The following is a description of a gene set: species: Mus musculus Mouse Gene Set: GOBP_NEGATIVE_REGULATION_OF_G_PROTEIN_COUPLED_RECEPTOR_SIGNALING_PATHWAY Any process that stops, prevents, or reduces the frequency, rate or extent of G protein-coupled receptor signaling pathway., and this is the list of marker genes: Bicd1, Sh2b3, Drd3, Ly6g6e, Pld2, Sag, Rgs4, Aplp1, Gipr, Ptger3, Padi2, Rgs13, Grk4, Ppp3ca, Necab2, Sstr4, Arrdc3, Plek, Palm, Dnm1, Rnf113a2, Becn2, Ywhab, Oprl1, Gnai2, Rnf113a1, Arrb2, Slit3, Grk5, Robo1, Dnm2, App, Cry1, Mrap2, Rgs12 (regulator of G-protein signaling 12), Rph3al (NCBI Gene Id 76242), Met, Camk2b, Grk2, Grm5, Inpp5a, Atp2b4, Arrb1, Oprm1, Rpgrip1l, Grk6, Ubqln2, Stmn1, Pde2a, Mgrn1, Snca, Arr3, Ada, Crtc3, Rgs14, Klk14, Gprasp1, Adrb2, Pde3a, Rgs2 (NCBI Gene Id 19735), Aplnr, Drd2, Mrap, Slit2, Rgs7, Apela, Ccl5, Grk3, Adm, Pde4d, Apln